Given this list of marker genes ETV1, PMS2, JAZF1, HOXA9 (NCBI Gene Id 94575), IKZF1, HOXA13, EGFR, HOXA11 (homeobox A11), here is a description of the gene set: from publication Myllykangas S, Himberg J, Böhling T, Nagy B, Hollmén J, Knuutila S (PMID 16751803) Human Gene Set: MYLLYKANGAS_AMPLIFICATION_HOT_SPOT_29 DNA copy number amplifications activate oncogenes and are hallmarks of nearly all advanced tumors. Amplified genes represent attractive targets for therapy, diagnostics and prognostics. To investigate DNA amplifications in different neoplasms, we performed a bibliomics survey using 838 published chromosomal comparative genomic hybridization studies and collected amplification data at chromosome band resolution from more than 4500 cases. Amplification profiles were determined for 73 distinct neoplasms. Neoplasms were clustered according to the amplification profiles, and frequently amplified chromosomal loci (amplification hot spots) were identified using computational modeling. To investigate the site specificity and mechanisms of gene amplifications, colocalization of amplification hot spots, cancer genes, fragile sites, virus integration sites and gene size cohorts were tested in a statistical framework. Amplification-based clustering demonstrated that cancers with similar etiology, cell-of-origin or topographical location have a tendency to obtain convergent amplification profiles. The identified amplification hot spots were colocalized with the known fragile sites, cancer genes and virus integration sites, but global statistical significance could not be ascertained. Large genes were significantly overrepresented on the fragile sites and the reported amplification hot spots. These findings indicate that amplifications are selected in the cancer tissue environment according to the qualitative traits and localization of cancer genes. studied in species Homo sapiens Amplification hot spot 29: colocolized fragile sites and cancer genes in the 7p22-p13 region.